Given this list of marker genes Prkaca, Saxo1, Trpa1, Lncbate10, Plin1, Abraxas2, Fcor, Ucp1, Slc9a1, Lipe, Cidea, Cirbp, Eif2ak4, Eif2ak3, Nfe2l1, Rnf34, Ces1d (carboxylesterase 1D), Dnajc3, Scn11a, here is a description of the gene set: studied in species Mus musculus Any process that results in a change in state or activity of a cell (in terms of movement, secretion, enzyme production, gene expression, etc.) as a result of a cold stimulus, a temperature stimulus below the optimal temperature for that organism. Mouse Gene Set: GOBP_CELLULAR_RESPONSE_TO_COLD